The following is a description of a gene set: Human Gene Set: GSE41867_DAY15_EFFECTOR_VS_DAY30_EXHAUSTED_CD8_TCELL_LCMV_CLONE13_DN studied in species Homo sapiens from publication Doering TA, Crawford A, Angelosanto JM, Paley MA, Ziegler CG, Wherry EJ (PMID 23159438) During acute viral infections, naïve CD8+ T cells differentiate into effector CD8+ T cells and, after viral control, into memory CD8+ T cells. Memory CD8+ T cells are highly functional, proliferate rapidly upon reinfection and persist long-term without antigen. In contrast, during chronic infections, CD8+ T cells become “exhausted” and have poor effector function, express multiple inhibitory receptors, possess low proliferative capacity, and cannot persist without antigen. To compare the development of functional memory T cells with poorly functional exhausted T cells, we generated longitudinal transcriptional profiles for each. Genes down-regulated in CD8 T cells during chronic infection with LCMV-Clone 13: effectors at day 15 versus exhausted at day 30., and this is the list of marker genes: WDR75, SNRPA1, TRAM2, DNAAF2, STRAP, INTS6, SEC24A, KLHL7, OGT, ORC1, FAM114A2, HACD1, PCMT1, MTFP1, FKTN, DCUN1D5, NOL11 (nucleolar protein 11), WDR55, WDR20, TRMT6, SLC11A2, WDR43, PWWP2A, SGSM3, ISYNA1, NMT2, RAD17, GFER, RNF138, NUS1, TMEM248, GPRASP3, TARDBP, ATP13A3 (ATPase 13A3), IFRD2, HERC1, EIF2S2, PPP1R14B, CDS2, TMEM108, ARID5B, NUP35, DLST, IRAK1, BCR, NAE1, ABHD17A, TMEM126B, RPN2, SELENOO, AASDHPPT, MOB3B, LIPT1, JMJD6, SLC35F2, ME2, CLPX, MTFR1, LSS, PDE7A, ZBTB25, MDC1, OTUD6B, ETF1, NUFIP1, WEE1, NT5C3B, PDK1, RAI1, NUDT5, TOP2B, KCTD13, MMGT1, PUS3, YES1, TBP, LSG1, JADE3, PPIF, ARMCX4, SPRTN, MKLN1, MKNK2, COMTD1 (catechol-O-methyltransferase domain containing 1), CHST10, C18orf54, MCMBP, ZDHHC20, ORMDL1, TNFSF9, TFDP1, RPAP2, JCAD, NARS2, CLDN12, TMOD1, GALC, DYM, USP16, CRISP3, ZFP36L1, TMEM97, CSNK1E, DHX32, SPINDOC, SCRIB, HAUS6, CECR2, RMND5A, TAF4, RINT1, EIF4E, MAPRE2, FBXL3, DPY19L1, ALKBH8, TCERG1, INO80C, SANBR, DDX46, MAPK6, DNMT3B, CTNNAL1, IRAK1BP1, PIAS2, GSPT1, GNL2, NCOA3, THAP4, NAF1, ZNF566, ZNF280C, MFSD14B, RBM48, IPO11, STT3A, MRPL54, GTF2E1, MTIF2, SNAP23, IKZF5, PPP2R5A, ZNF597, ADNP, TSEN54, UBXN8, SRFBP1, POLR1F, EML4, RAB18 (RAB18, member RAS oncogene family), GNAQ, KCNK13, MAK16, RUFY1, NPM3, HMGCR, SLC30A4, LURAP1, SENP6, ADAM17, TSPAN6, EIF1AY, IL6ST, TAF5, OXR1, PRDM5 (NCBI Gene Id 11107), SRSF7, NDUFS1, PTER, TXNDC5, GCAT, ATP6V1F, FOXO3, RNFT1, NUDT17, ZBTB2, LEMD3, RMC1, GABPA, ETAA1, EYA1, LARP7, GGACT, UBXN2A, TMED2, SDC1, LATS1, ECHDC1, GCLC, MOB2, SLC25A51, EIF2AK3, PREP, ST8SIA6, UCHL3, GPR89B, SCAMP2, ZNF347, CDC5L, HIBCH